The following is a description of a gene set: Any process that results in a change in state or activity of a cell or an organism (in terms of movement, secretion, enzyme production, gene expression, etc.) as a result of exposure to aversive or demanding psychological and social conditions that tax or exceed the behavioral resources of the organism. species: Homo sapiens Human Gene Set: GOBP_RESPONSE_TO_PSYCHOSOCIAL_STRESS, and this is the list of marker genes: GLP1R, GRIA1 (glutamate ionotropic receptor AMPA type subunit 1), PRKCG, ADRB2, HSF1 (NCBI Gene Id 642255)